The following is a description of a gene set: An instance of double-strand break repair via nonhomologous end joining that requires a number of factors important for V(D)J recombination, including the KU70/80 heterodimer (KU), XRCC4, ligase IV, and DNA-PKcs in mammals. It does not produce translocations (as opposed to the alternative nonhomologous end joining). Human Gene Set: GOBP_DOUBLE_STRAND_BREAK_REPAIR_VIA_CLASSICAL_NONHOMOLOGOUS_END_JOINING studied in species Homo sapiens, and this is the list of marker genes: TOPBP1, XRCC6, ERCC8, ZBTB7A, LIG4, UVRAG, RNF168, TP53BP1, ERCC6, ERCC6L2